The following is a description of a gene set: from publication Chen Y, Wang X (PMID 31504780) Human Gene Set: MIR660_3P Genes predicted to be targets of miRBase v22 microRNA hsa-miR-660-3p in miRDB v6.0 with MirTarget v4 prediction scores > 80 (high confidence targets). species: Homo sapiens, and this is the list of marker genes: QRICH2, SP7, RNF24, TNRC6B, NLGN1, TMED9, CABLES1, HRH2, KCNQ5 (NCBI Gene Id 56479), DGKH, HDAC9, AIFM1, CRKL, KERA, SPANXN1, DNTT, POGLUT1, GDNF, SRP19, RPS3A, DPP10, COL8A2 (collagen type VIII alpha 2 chain), SARM1, PDP2, ZNF862 (zinc finger protein 862), ZNF587B, SAP30L, TCP10L2, ADD1, SPANXN5, AFF1, GTPBP8, ORAI2, NAT9, UBR2, KSR2, PPP1R1B, BAGE2 (BAGE family member 2 (pseudogene)), ZNF728, CPT2, EFNB3, SPG11, CAMTA1, CPLX2, TSC1, CACNG8, GPD1, SLC35F1, YY1, STOX2, RIMS4, MMP14, ZC3H11A, VASH2, NDOR1 (NCBI Gene Id 648245), RAB3B (RAB3B, member RAS oncogene family), MMP20, SCN8A, MICALL1, ZPLD1, UBN2, MMS22L, NFIC, GRM1, IQSEC2, EPHB2, SWI5, GDAP1L1, TNFSF10, DYRK1A, CRELD2, MBNL2, STT3A, RGS3, IKZF3, RASSF1, NOL9, TRNP1, SLC38A5, LDB2, HMGB1, IGF2, HOMER1, NRBP1 (NCBI Gene Id 29959), ERG, WDTC1, EID1, PSG7, KIAA1958, MYZAP, NEDD4L, CCDC9B (coiled-coil domain containing 9B), SLC16A2, RALB, WNT9B, TNFSF15, CNTFR, ACACA, TEP1